Given this list of marker genes CYP19A1 (NCBI Gene Id 1588), HOXD13, DNAJC19, TYRO3, LHCGR, TBX3, BAK1, NIPBL, TIFAB, SRD5A1, KLHL10, CHD7, SYCP2, WNT5A, HSD17B3, PKD1 (NCBI Gene Id 5310), AR, STRA6, LHX1, BMP6, BAX, RBP4, ESR1, WNT9B, GREB1L (NCBI Gene Id 80000), DCANP1, NEUROG1, FGF8, AXL, HOXA13, LGR4, HNF1B, DHCR24, PTPN11, ASB1, BMP5, SHH, MERTK, CTNNB1, FOXF2, WT1, SRD5A2, NPR2, LRP2, FGF10, PDGFRA, TP63, here is a description of the gene set: species: Homo sapiens Human Gene Set: GOBP_GENITALIA_DEVELOPMENT The process whose specific outcome is the progression of the genitalia over time, from its formation to the mature structure.